Given this list of marker genes B4GALT4 (NCBI Gene Id 8702), B4GALT3, GCNT2, B3GNT3, B4GALT1, B3GNT4, B3GNT2, here is a description of the gene set: Pathway Definition from KEGG: nLc4Cer -- B3GNT2/3/4 >> B4GALT1/3/4 -> i_antigen -- GCNT2*I -> I_antigen Human Gene Set: KEGG_MEDICUS_REFERENCE_II_BLOOD_GROUP_ANTIGEN_BIOSYNTHESIS Ii blood group antigen biosynthesis. Pathway ID: N01678. Pathway type: Reference. Pathway class: nt06035 Blood group carbohydrate antigen biosynthesis. studied in species Homo sapiens